The following is a description of a gene set: studied in species Homo sapiens from publication Chen Y, Wang X (PMID 31504780) Genes predicted to be targets of miRBase v22 microRNA hsa-miR-2355-5p in miRDB v6.0 with MirTarget v4 prediction scores > 80 (high confidence targets). Human Gene Set: MIR2355_5P, and this is the list of marker genes: ZNF189, RAB1B, FAF2, PDCD2 (programmed cell death 2), PARVA, TNRC6B (NCBI Gene Id 23112), MEF2C, DHRS4L2, AMIGO1, PABPN1, SMARCD1, PRPS1, PHB2, MRM2, RBBP9, TRPM4, TBKBP1, KLF3, SLC1A4, NACC1 (NCBI Gene Id 112939), HNRNPR, ZHX2, ARHGAP19, NEURL1B, CREB3L2 (NCBI Gene Id 64764), BTG2, CFAP65, EDARADD, BTG1, SOX6, NEURL3, ADH1C, FZD7, SOCS7, FAM217B, FAM8A1, WDR20, STAU2, CACNA1E, TLK2, KCNIP3, KRTAP2-3, TMEM132B, DNAJC6, SRSF1, SLC22A23, ZBTB46, DPYSL2, PIK3CD, PHF8, RFX3 (regulatory factor X3), NDST1, BCL2L2-PABPN1, GGA3, AGFG1, PPIP5K1, ZNF354C, PERP, NAXD (NCBI Gene Id 95526), TLR6, ICAM4 (intercellular adhesion molecule 4 (Landsteiner-Wiener blood group)), TSR1, WSCD2, SH3TC2, DNAJB2, SPIDR, DAAM2, CBL, DHRS4, TIAM1, NF2, ASPHD2, CHD8, STMN1, SGPP2, ZNF629 (NCBI Gene Id 7616), ATP1B4, WIPF2, CERS2, IQCE, RAB5IF, TMTC1 (NCBI Gene Id 83857), MAP3K10, SIGMAR1, ARHGAP36, DMAC1, ERF, FRYL, CHEK1 (checkpoint kinase 1), RASL10B, ZNF99, GATAD2B, CLSTN3, AHCYL1, TMEM30B, AGO1 (NCBI Gene Id 26523), VASP, LRTM2, LHFPL5, KLF6, DIPK2B, EYA1, LRRC75A, CHD2, VMP1, KCNE4, TAF13 (TATA-box binding protein associated factor 13), GPATCH2, NT5C3A, PRDM11, GPAM, PAQR5, NBL1, ZNF664, RHBDL3, MYO9A, TTBK2, DNMT3B, RAB27B, SGMS1, ABI3BP (ABI family member 3 binding protein), PCDH19, DIXDC1, TMX3, MIPOL1, ZBTB4, TRAF7, PHF21A, AFF2, NR4A3, LMX1A, RFC2, DIAPH1